The following is a description of a gene set: species: Mus musculus Mouse Gene Set: GOBP_MICROTUBULE_CYTOSKELETON_ORGANIZATION A process that is carried out at the cellular level which results in the assembly, arrangement of constituent parts, or disassembly of cytoskeletal structures comprising microtubules and their associated proteins., and this is the list of marker genes: Plk5, Bcl2l10, Kat2a, Eml4, Cyld, Slk, Dctn2, Abraxas1, Ooep, Mtcl1, Map7d2, Cfap43, Ptk2, Cfap100, Bmerb1, Meig1, Map4, Nckap5l, Cep44, Cetn3, Apc2, Washc1, Pdcd6ip, Rp1, Itgb1, Cep68, Katnal2, Inppl1, Cep192, Fbxw11, Dync1li2, Daw1, Tubb4b (tubulin, beta 4B class IVB), Pax6, Akap9, Cdk11b, Stmn1, Kash5, Fam110a, Wdr62, Rbm14, Ranbp1, Gm5890, Tmem67, Gas2l3, Aurkc, Dag1, Foxj1, Gsk3b, Ilk, Bbs2, Flna, Abl1, Poc1b, Fgf10, Map7d1, Spire1, Dnaaf1, Golga2, Kif14, Cdc14b, Htt, Birc5, Ccsap, Mark4, Calml4, Tubgcp6, Cfap69 (cilia and flagella associated protein 69), Llgl2, Ttbk2, Mzt1, Lrrc23, Ccdc88c, Chmp7, Tbcel, Dicer1, Sik3, Rsph6a, Ccdc42, Specc1l, Clip2, Cenpj, Rsph1, Cep43, Pard3b, Camsap2 (NCBI Gene Id 75184), Cep70, Ccdc65, Mapre3, Ino80, Cltc, Kat5 (K(lysine) acetyltransferase 5), Rangrf, Haus1, Clip3, Plk2, Tubd1, Cdk2ap2, Stk36, Rcc1, Nme7, Mei1, Dnai4, Syne2, Ttl, Gapdh, Fbxo5, Cep135, Mdm1, Spag6, Dync1h1, Clasp1, Ttll11, Fsip2, Gadd45a, Ofd1, Odad3, Aunip, Cenatac, Tbce, Bcas2, Mark3, Haus4, Ndc80, Sbds, Cep120, Wdr47, Dcx, Dnal1, Poc5, Dctn1, Spag1, Snca (NCBI Gene Id 20617), Cdc14a, Spast, Slc39a12, Cep19, Pibf1, Stag2, Pdcl2, Nin, Map7, Ccdc40, Bbof1, Senp6, Hepacam2, Efhc1, Psrc1, Cntrob, Crocc, Hook1, Stmnd1, Ttll6, Cdkn1b, Ctnnb1, Camsap1, Chmp2a, Chmp6, Prc1, Gas2l1, Cdk5r1, Cfap44 (cilia and flagella associated protein 44), Katna1, Tubb5, Tubg2, Prkcz, Setd2, Nefm, Nav1, Cfap65, Nefh, Dnah17, Phldb2, Stmn3, Ttll3, Ttll5, Dnah1, Map7d3, Cep295, Tacc1, Cep131, Bicd1, Fes, Tbc1d21, Ninl, Ccdc88a, Kiz, Cav3, Tuba1a, Cdk2, Limk2, Uvrag, Npm1, Chmp3, Rttn, Pafah1b1, Nudc, Atrx, Brsk1, Map9, Mlh1, Septin1, Tle6, Misp, Drc1, Stil, Cep85, Cdk1, Pde4dip, Ift56, Ankrd53, Axin1, Map6 (NCBI Gene Id 17760), Cc2d2a, Pkd1, Cdk5rap2, Capn6, Map6d1, Chek2, Spry2, Cfap73, Gtf2b, Nuf2, Cfap206, Fam107a, Mns1, Diaph3, Tubb2b, Ift88, Hdgfl3, Map1s, Hook3, Zpr1, Mapt, Dvl1, Sac3d1, Poldip2, Ccdc170, Pkhd1 (polycystic kidney and hepatic disease 1), Ccdc103, Drg1, Tubb2a, Chd3, Tube1, Hydin, Gapdhrt, Kif2a, 4933427D14Rik, Stard9, Fbxo24, Spag16, Racgap1, Rp1l1 (NCBI Gene Id 613256), Kif3b, Gas8, Fgf13, Gm4513, Katnal1, Sass6, Bbs4, Ska2, Tekt2, Ss18, Rab11a, Numa1, Smc1a, Ppp1r35, Iqcg, Katnbl1, Knstrn, Hspa1b, Sapcd2 (suppressor APC domain containing 2), Gda, Smn1 (NCBI Gene Id 20595), Ift46, Pex14, Azin1, Kif21a, Rock1, Ccdc13, Spag5 (sperm associated antigen 5), Slc16a1, Gpsm1, Aspm, Washc5, Rsph4a, Smc3, Clip1, Rps3, Cenpe, Apc, Dnaaf6, Trim37, Aurka, Tuba3a, Map10, Hdac6, Kif18a, Afg2b, Rsph9, Csnk1d, Fbxw5, Gsk3a, Ints13, Hspa1a (heat shock protein 1A), Tpr, Odad4, Tppp, Kif23, Bccip, Dnah7b, Plk4, Ccnl1, Rac1, Kifbp, Ak7, Ccnb1, Cetn2, D7Ertd443e, Arhgef10, Ttll8, Fmn2, Ttll13, Cplane2, Tln1, Ccdc61, Tacc3, Kif20a, Pierce1, Dync1li1, Wdr73, Ccnf, Map1a, Trim36, Tubb4a, Map1b, Dnaaf10, Ripor2, Ulk4, Tubgcp3, Alms1, Gapdhrt2, Bbs1, Spire2, Ubxn2b, Aurkb, Pierce2, Lmna, Mark2, Pcm1, Gm6176, Pard3 (par-3 family cell polarity regulator), Trpv4, Ttc12, Dnaaf5, BC034090, Chordc1, Ppp2r1b, Sgk1 (NCBI Gene Id 20393), Fignl2, Dnaaf3, Phldb1, Mapk8, Tubgcp4, Pard6a, Dynlt1b, Cep20, Incenp, Trdn, Ndel1, Zmynd12, Parp3, Cep72, Mecp2, Cdc20, Gpsm2, Haus7, Nat10, Tbc1d32, Ccp110, Plk1, Kpnb1, Cgn, Xpo1, Spdl1, Ttll7, Disc1, Dctn6, Calm4, Traf3ip1, Cep152 (centrosomal protein 152), Gm6882, Kif3a, Ube2b, Bora, Pard6g, Cenph, Bnip2, Ptpa, Cfap47, Ppfibp1, Clasp2, Txndc9, Ccdc78, Pak1, Stmn2, Ccdc66, Spry1, Zfp207, Ska1, Katnb1, Ddb1, Chmp1b, Mid1ip1, Espl1, Tubal3, Fsd1 (fibronectin type 3 and SPRY domain-containing protein), Spaca9, Ccnl2, Gm5157, Slain1, Ccdc15, Brsk2, Deup1, Ppp2r1a, Cdca8, Cryab, Dnaaf2, Cep295nl, Chp1, Ttll1, Cdc20b, Lrguk, Lsm14a, Vps4b, Gabarap, Wee1, Ccdc68, Dnm2, Chmp5, Spc25, Jhy, Rhoa, Myh9, Eml2 (NCBI Gene Id 72205), Prkaa1, Ccn2, Tuba1c, Cdh5, Nefl, Agrn, Sirt1, Khdc3, Dnah7c (NCBI Gene Id 100101919), Ncor1, Cep126, Haus6, Pcnt, Rgs14, Cep290, Gba2, Gcc2, Kif2b, Stag1, Tubb6, Tubb3, Cep76, Trim46, Wdr72, Tubgcp5, Zbed3, Cib1, Mcph1, Ttll9, Cep250, Mybl2, Xrcc3, Pla2g3, Zw10, Rock2, Dixdc1, Chek1, Aaas, Kifc5b, Ccnb2, Gm10668, Ccdc69 (coiled-coil domain containing 69), Spag17, Met (met proto-oncogene), Kif4, Dnah2, Gm10662, Clip4, Sugt1, Arhgef1, Tubb1, Cfap58, Cfap91, Tppp3, Ccdc187, E2f4, Ranbp10, Dyrk1a, Kif15, Dnaaf11, Mapre1, Kif11 (kinesin family member 11), Cluap1, Prkaa2, Itgb1bp2, Taok1, Cetn1, Kif19a, Inpp5j, Sgo1, Mapk15 (NCBI Gene Id 332110), Hoatz, Calm5, Dnaaf4, Sdccag8, Gen1, Tpx2, Poc1a, Cript, Enkd1, Wrap73, Abraxas2, Uxt (NCBI Gene Id 319632), Chmp4b, Spata7, Ank3, Pten, Efna5, Map2, Brca1, Uhrf1, Nckap5, Dnai2, Dnaaf6rt, Ccdc120, Tubg1, Arl2, Arhgef2, Neurl1a, Cep350, Cav1, Lrrc46, Chmp1b2, Sun1 (Sad1 and UNC84 domain containing 1), Cul7, Ckap5, Mcidas, Ezr, Drc7, Eml3, Wdr90, Fsip1, Dnah7a, Haus2, Camsap3, Cenpa, Llgl1, Tpgs1, Rae1, Chmp1a, Ccnb1-ps (cyclin B1, pseudogene), Dnai1, Vcp, Haus5, Cdc42bpa, Htr1a, Ift172, Nup62, Ssna1 (SS nuclear autoantigen 1), Ssx2ip, Kif18b, Pard6b, Nav3 (NCBI Gene Id 676640), Ckap2, Tbcb, Usp33, Atat1, Tppp2, Nubp1, Dclk2, Ttll2, Tuba8, Tubgcp2, Spag6l, Cep63, Eml1, Fkbp4 (FK506 binding protein 4), Odad1, Prune1, Dnajb13, Rho, Efcab11, Hnrnpu, C2cd3, Arhgef7, Trim54, Son, Ccdc39, Cfl1, Cfap74, Hsph1, Cntln, Dzip1 (DAZ interacting protein 1), Zmynd10, Brca2, Atf5, Togaram1, Xrcc2, Cfap57, Dst, Dock7, Obsl1, Srgap2, Slain2, Dnai3, Spef1, Togaram2, Dlgap5, Ankfn1, Nusap1, Cetn4, Ttll4 (tubulin tyrosine ligase-like family, member 4), Mid1, Ska3, Wnt3a, Sun2, Ppp1r12a, Cfap157, Ntmt1, Spef2, Ccdc63, Mad2l1, Ppp2r3c, Tuba1b, Nedd1, Ccdc57, Kif2c, Clxn, Cntn2, Lrrc61, Odad2, Armc2, Ccdc88b (NCBI Gene Id 78317), Mapre2, Chmp2b, Cfap97d1, Atxn7 (NCBI Gene Id 78432), Nlrp5, Bicd2, Fer, Haus8, Dnah5, Haus3, Mos, Stmn4, Atxn3, Tbcd, Pclaf, Rnf4, Plk3, Epha3, Lzts2, Nde1, Prickle1, Gnai1, Chmp4c, Nsfl1c, Dlg1, Cul9, Git1, Snhg15 (NCBI Gene Id 100041286), Ccser2, Nek2, Tacc2, Ccdc8 (NCBI Gene Id 654778), Gja1, Kifc1, Kat2b, Gas2l2 (growth arrest-specific 2 like 2), Spice1, Hook2, Dnah8, Tuba4a, Kif24, Hdac3, Cep97, Dcaf13, Cc2d1a